Given this list of marker genes ANPEP, MADCAM1, PRKCI, KLF6, MAP3K1, NCOA3, TGFB1, EIF2AK2, STK25, PPP5C, MAP2K3, TGFB2 (NCBI Gene Id 7042), YWHAE, IGHV5-78, PTPN14, RAB5C, PRKCD, CSNK1G2 (casein kinase 1 gamma 2), RYBP, HSPA1L, PDS5B, BCL2L1, CDC42BPA, here is a description of the gene set: studied in species Homo sapiens Hepatitis B virus (HBV) is a major risk factor for the development of hepatocellular carcinoma (HCC). HBV encodes the potentially oncogenic HBx protein, which mainly functions as a transcriptional co-activator involving in multiple gene deregulations. However, mechanisms underlying HBx-mediated oncogenicity remain unclear. To determine the role(s) of HBx in the early genesis of HCC, we utilized the NCI Oncochip microarray that contains 2208 human cDNA clones to examine the gene expression profiles in either freshly isolated normal primary adult human hepatocytes (Hhep) or an HCC cell line (SK-Hep-1) ecotopically expressing HBx via an adenoviral system. The gene expression profiles also were determined in liver samples from HBV-infected chronic active hepatitis patients when compared with normal liver samples. The microarray results were validated through Northern blot analysis of the expression of selected genes. Using reciprocally labeling hybridizations, scatterplot analysis of gene expression ratios in human primary hepatocytes expressing HBx demonstrates that microarrays are highly reproducible. The comparison of gene expression profiles between HBx-expressing primary hepatocytes and HBV-infected liver samples shows a consistent alteration of many cellular genes including a subset of oncogenes (such as c-myc and c-myb) and tumor suppressor genes (such as APC, p53, WAF1 and WT1). Furthermore, clustering algorithm analysis showed distinctive gene expression profiles in Hhep and SK-Hep-1 cells. Our findings are consistent with the hypothesis that the deregulation of cellular genes by oncogenic HBx may be an early event that favors hepatocyte proliferation during liver carcinogenesis. Human Gene Set: WU_HBX_TARGETS_1_DN from publication Wu CG, Salvay DM, Forgues M, Valerie K, Farnsworth J, Markin RS, Wang XW (PMID 11439330) Genes down-regulated by expression of HBV X protein (HBVgp3) in SK-Hep-1 cells (hepatocellular carcinoma).